The following is a description of a gene set: species: Homo sapiens Genes predicted to be targets of miRBase v22 microRNA hsa-miR-1911-5p in miRDB v6.0 with MirTarget v4 prediction scores > 80 (high confidence targets). from publication Chen Y, Wang X (PMID 31504780) Human Gene Set: MIR1911_5P, and this is the list of marker genes: DLC1, G3BP2, EIF2AK2, GPR45, DERA, GJA1, BICD2, SUSD6, FANCD2OS, FUT8, KRTAP24-1, NKAPD1, SMARCA1, B3GNT2, ARHGEF33, DISC1, LMTK2, CRIP3, SERF2 (NCBI Gene Id 88287), FRS2, CTC1, SYTL4, RASA2, C6orf62, PDIK1L, ZNF93, CSMD3